The following is a description of a gene set: Abnormality of iron homeostasis An abnormality of the homeostasis (concentration) of iron cation. Human Gene Set: HP_ABNORMALITY_OF_IRON_HOMEOSTASIS studied in species Homo sapiens, and this is the list of marker genes: PIGA, ABCD3, BMP6, PKLR, FTL, ALAS2, SKIC3, TFR2, TMPRSS6, HJV, FOXP1, HFE, SLC25A38, SLC30A10, BCS1L, FTH1, TRNT1, SLC11A2, BMP2, STEAP3, CP, HBB, RACGAP1, SLC40A1, COL7A1, KIF23, CARD9, STAB1, HAMP, SKIC2